The following is a description of a gene set: species: Homo sapiens An increase in size of the anatomic space between the arachnoid membrane and pia mater in the region surrounding the cerebellum. Widened cerebellar subarachnoid space Human Gene Set: HP_WIDENED_CEREBELLAR_SUBARACHNOID_SPACE, and this is the list of marker genes: TSEN34, SEPSECS, NMNAT1, TSEN54, TSEN15, TSEN2